The following is a description of a gene set: studied in species Homo sapiens from publication Baram D, Dekel O, Mekori YA, Sagi-Eisenberg R (PMID 20190146) We demonstrate that the G protein Gi3 is the cellular target of the adenosine A3 receptor (A3R). By using a cell permeable peptide comprising the C-terminal end of Gαi3 fused to an importation sequence (ALL1) as a selective inhibitor of Gi3 signaling, we show that by coupling to Gi3, the A3R stimulates multiple signaling pathways in human mast cells, leading to upregulation of cytokines, chemokines and growth factors.Following contact with activated T cell membranes, endogenous adenosine binds to and activates the A3R, resulting in Gi3-mediated signaling. Specifically, the majority of ERK1/2 signaling initiated by contact with activated T cell membranes, is mediated by Gi3, giving rise to ALL1-inhibitable cellular responses. These results unveil the physiological GPCR that couples to Gi3 and establish the important role played by this G-protein in inflammatory conditions that involve adenosine-activated mast cells. We used microarrays to detail the effect of ALL1 on gene expression of HMC-1 cells activated directly by the A3 receptor, or by contact with activated T cell membranes. Genes up-regulated in HMC-1 (mast leukemia) cells: untreated versus incubated with the peptide ALL1 followed by treatment with Cl-IB-MECA. Human Gene Set: GSE19888_CTRL_VS_A3R_ACT_TREATED_MAST_CELL_PRETREATED_WITH_A3R_INH_UP, and this is the list of marker genes: SERPINH1, LIN28A, FANCF, ZNF354C, TRIM37, CNEP1R1, ARMCX4, BATF3, KRTAP21-1, KRT33B, VXN (NCBI Gene Id 254778), SERPINF2, SRPX, CCDC82, CHCHD5, TBC1D31, ENTPD2, NADK2, SORCS3, LCK, GUCA1A, SDK2, GAS6, LRRC4C, LAPTM4A, KCNK10, ZIK1, PRPSAP2, LRAT, REV3L, C1QTNF2, HLA-DRA, LRCH2, EIF2AK3, SPRING1, OR5D18, PIR, TECRL, KCNT1, TBXA2R, VPS13C, BMP8A, FKBP15, C19orf73, NLRP14, IQCF5, CD34, FYN, SDF2L1, METTL1, TDRD1, ZKSCAN8P1, DNAJB14, ANAPC13, GSS, CCDC54, WBP4, ARHGEF25, GREB1, MAP3K14, CATSPER2, TSPAN13, OLFML2B, F8A1, HBG2, LYZL4, TINAGL1, AKR1C3, PENK, DMRT1 (NCBI Gene Id 82031), ADI1, RPN1, TUB, CXCR5, DYM, IL11RA, HTR7, SCML4 (NCBI Gene Id 256380), FCAMR, OIT3, FOXC1, LRRC36, MCHR1, OOEP, CHMP6, PJA2, DPY30, HOXB7, RIMKLA, KMT2C, NSG2, COX14, GSTK1, GLRX5, KPNB1, CHRNG, RGS7BP, FKBP2, CEACAM21, BAG5, RNF166, SPOCK2, MBP, GRPR, P3H3, MEST, KCNE4, ZNF205, CST8, ZNF768, LOXL4, ZC3H14, TP53I13, CLPTM1L, IPP, NLRC3, HS6ST3, RPS29, NRG2 (neuregulin 2, NCBI Gene Id 9542), FMR1NB, ITGAV, ROCK2, TMED9, DNAJB13, RNF151, INHBE, UBXN6, MMP12, LIMA1, PILRB, SNAPC5, CCDC115, MRPS35, TMEM150C, GREM2, MSANTD4, SGTB, RHBDL1, ANXA5, TMEM176A, CPXM1, MCEE, TGFB1I1, SSTR3, SPOPL, PSD, PLEKHJ1, DIDO1, TTLL5, TAF5L, EMID1, SUCLG2, WDR86, SYNGR4, AGTR1, ZNF764, SSC5D, C4BPB, TERF2IP, DQX1, CELA2A (chymotrypsin like elastase 2A), SNX17, SFRP5, PROSER2, KCNJ1, CCDC17, CRTAP, DLL3, FAM13C, C1QL2, IGLON5, GXYLT2, FUT4, BCL2L14, NLRP4, FMNL1, XAB2, GALNT14, SULT1E1, GP6, DOCK1, STEAP3, TCF7L1, SPCS3, SH2D1A, RBP1, EFEMP2, PTAFR, ADGRL3, SFRP1, NKD2, LRRC66, SSTR4, STK38, AXL, EIF3F, SLC12A5, OTUD7B, MIEN1